The following is a description of a gene set: species: Homo sapiens Human Gene Set: HP_HYPERPITUITARISM Hyperpituitarism Hypersecretion of one or more pituitary hormones. This can occur in conditions in which deficiency in the target organ leads to decreased hormonal feedback, or as a primary condition most usually in connection with a pituitary adenoma., and this is the list of marker genes: SLC30A7, ZMYND15, TEX14, FANCM, MCM8, TAF4B, HSD17B4, C14orf39, PNLDC1, CDKN2C, SYCE1, VAMP7, SMARCE1, PIK3CA, SYCP3, SYCP2L, GDF9, PSMC3IP, PDHA2, TERB2, SHOC1, ESR1, GCNA, CDH23, NSMCE2, MEN1, HPGD, IGF1, FSHR, TERB1, TRAF7, NR5A1, POLA1, LHB, POR, FGD1, ZFPM2, CCDC34, KISS1R, DDC, CYP11A1, KASH5, MSH4, FOXL2, PPP2R3C, NR0B1, POLR3A, DNAH10, HSD3B2, BAP1, TRHR, CDKN2B, DNHD1, ZSWIM7, ERCC6, BMP15, FMR1, RNF212, AIP, TP63 (NCBI Gene Id 8860), MEIOB, HROB, WT1, GPR101, SMO, STAG3, MSH5, CLPP, CATIP, PRLR, XRCC2, NUP107, CNBP, PDE11A, AR, NANOS1, PDGFB, MCM9, SPAG17, ABCD1, ESR2, SPIDR (NCBI Gene Id 23514), PRKAR1A, CYP17A1, DHH, BNC1, CFTR, TSHB, FSHB (NCBI Gene Id 2488), CDKN1B, DIAPH2, POLR3H, BRAF, BMPR1B (NCBI Gene Id 658), FIGLA, DHX37, CYB5A, TEX11, LARS2, PMM2, HFM1, AKT1, FKBP6, NF2, SMARCB1, SOHLH1, GNAS, GATA4, RPL10L, MCM4, KCNJ11, CT55, SLCO2A1, MRPS22, LHCGR, TEX15, CTNNB1, SOX9, CBX2, KLHL10, SUFU, CDKN1A, SRY, SPATA22, FBXO43, TERT, WWOX, MSTO1, MOV10L1, TDRD9, MAP3K1